Given this list of marker genes Slc7a6 (solute carrier family 7 (cationic amino acid transporter, y+ system), member 6), Slc22a5, Slc38a2, Slc25a20, Slc22a15, Slc16a9, Slc22a16, Slc6a20a, Slc22a1, Slc22a4, Slc6a14, Slc6a12, Slc25a29, Slc22a21 (solute carrier family 22 (organic cation transporter), member 21), here is a description of the gene set: The directed movement of betaine, the N-trimethyl derivative of an amino acid, into, out of or within a cell, or between cells, by means of some agent such as a transporter or pore. species: Mus musculus Mouse Gene Set: GOBP_AMINO_ACID_BETAINE_TRANSPORT